The following is a description of a gene set: Any process that results in a change in state or activity of a cell or an organism (in terms of movement, secretion, enzyme production, gene expression, etc.) as a result of a disaccharide stimulus. studied in species Homo sapiens Human Gene Set: GOBP_RESPONSE_TO_DISACCHARIDE, and this is the list of marker genes: CALCRL, NAGLU, PNPLA3, ADIPOQ, OXT, GRIA1, KHK